The following is a description of a gene set: Genes with intermediate-CpG-density promoters (ICP) bearing histone H3 trimethylation mark at K4 (H3K4me3) in neural precursor cells (NPC). DNA methylation is essential for normal development and has been implicated in many pathologies including cancer. Our knowledge about the genome-wide distribution of DNA methylation, how it changes during cellular differentiation and how it relates to histone methylation and other chromatin modifications in mammals remains limited. Here we report the generation and analysis of genome-scale DNA methylation profiles at nucleotide resolution in mammalian cells. Using high-throughput reduced representation bisulphite sequencing and single-molecule-based sequencing, we generated DNA methylation maps covering most CpG islands, and a representative sampling of conserved non-coding elements, transposons and other genomic features, for mouse embryonic stem cells, embryonic-stem-cell-derived and primary neural cells, and eight other primary tissues. Several key findings emerge from the data. First, DNA methylation patterns are better correlated with histone methylation patterns than with the underlying genome sequence context. Second, methylation of CpGs are dynamic epigenetic marks that undergo extensive changes during cellular differentiation, particularly in regulatory regions outside of core promoters. Third, analysis of embryonic-stem-cell-derived and primary cells reveals that 'weak' CpG islands associated with a specific set of developmentally regulated genes undergo aberrant hypermethylation during extended proliferation in vitro, in a pattern reminiscent of that reported in some primary tumours. More generally, the results establish reduced representation bisulphite sequencing as a powerful technology for epigenetic profiling of cell populations relevant to developmental biology, cancer and regenerative medicine. species: Mus musculus Mouse Gene Set: MEISSNER_NPC_ICP_WITH_H3K4ME3 from publication Meissner A, Mikkelsen TS, Gu H, Wernig M, Hanna J, Sivachenko A, Zhang X, Bernstein BE, Nusbaum C, Jaffe DB, Gnirke A, Jaenisch R, Lander ES (PMID 18600261), and this is the list of marker genes: Nosip, Triqk, Ppp2r3c, Zik1 (NCBI Gene Id 22775), 4833420G17Rik, Wdr83os, Fv1, Rpl19, Tbc1d22b, Atp6v1g2, Stoml1, Rttn, Rab13, Rbm4, 2810408A11Rik, Fam3a, Lsg1, Mpi, Tlr2, Prpf31, Drc3